The following is a description of a gene set: Genes whose expression is coregulated with that of RUNX1 in hematopoietic stem cells (HSC). We combined large-scale mRNA expression analysis and gene mapping to identify genes and loci that control hematopoietic stem cell (HSC) function. We measured mRNA expression levels in purified HSCs isolated from a panel of densely genotyped recombinant inbred mouse strains. We mapped quantitative trait loci (QTLs) associated with variation in expression of thousands of transcripts. By comparing the physical transcript position with the location of the controlling QTL, we identified polymorphic cis-acting stem cell genes. We also identified multiple trans-acting control loci that modify expression of large numbers of genes. These groups of coregulated transcripts identify pathways that specify variation in stem cells. We illustrate this concept with the identification of candidate genes involved with HSC turnover. We compared expression QTLs in HSCs and brain from the same mice and identified both shared and tissue-specific QTLs. Our data are accessible through WebQTL, a web-based interface that allows custom genetic linkage analysis and identification of coregulated transcripts. studied in species Mus musculus Mouse Gene Set: BYSTRYKH_HEMATOPOIESIS_STEM_CELL_RUNX1 from publication Bystrykh L, Weersing E, Dontje B, Sutton S, Pletcher MT, Wiltshire T, Su AI, Vellenga E, Wang J, Manly KF, Lu L, Chesler EJ, Alberts R, Jansen RC, Williams RW, Cooke MP, de Haan G (PMID 15711547), and this is the list of marker genes: Prss3, Phox2b, Ephb3, Pgr, Csf1r-ps, Acvrl1, Cd55, Il12rb2